The following is a description of a gene set: The apical end of the lateral plasma membrane of epithelial cells. Human Gene Set: GOCC_APICOLATERAL_PLASMA_MEMBRANE species: Homo sapiens, and this is the list of marker genes: TMEM114, CLDN3, MTCL1, ZG16B, CXADR, CTNNB1, OCLN, EPPK1, SLC28A2, CDH2, CLDN5, CRB2, KRT8 (NCBI Gene Id 90177), THBD, CLDN7, NEDD4, FZD6, CLDN6 (NCBI Gene Id 9074), KRT19, PALM, CLDN8, MPDZ, CLDN4